Given this list of marker genes Nedd4, Pde12, Ppp2ca, Fance, Ube2e1, Tuba3b, Cdk1, Trp53, Fancg, Tubb4a, Mx2, Prkra, Ilf3, Ikbkb, Cenps, Hspa1a, Map2k6, Snca, Tubb3, Npm1, Dnajc3, Hspa8, Fancb, Eif4a1, Eif4e2 (eukaryotic translation initiation factor 4E member 2), Eif2ak2, Ube2l6, Tubb2a, Chuk, Ppp2r1a, Tuba1b, Isg15, Faap100, Faap20, Fanca, Eif4g2, Tuba4a, Eif4e3, Ikbkg, Ppp2r1b (NCBI Gene Id 73699), Ube2n, Stat3, Ppp2cb, Tarbp2, Ppp2r5a, Fancm, Eif4g3, Oasl1, Tubal3, Adar, Fancc, Tubb1, Tuba3a, Dus2 (dihydrouridine synthase 2), Rigi, Faap24, Dhx9, Ilf2, Ppm1b, Tuba8, Mapt, Cenpx, Abce1, Fancl, Mavs, Arih1, Uba7, Eif4e, Eif4a2, Hspa1b (heat shock protein 1B), Rnasel, Hspa2, Fancf, Irf3, Hspa1l, Tubb4b, Tuba1a, Tubb2b, Usp18, Flnb, Plcg1, Tubb6, Becn1, Eif4a3, Nck1, Ifit1bl2, Sphk1, Tuba1c, Trim25 (tripartite motif-containing 25), Mapk3, Ptpn2, Eif4g1, here is a description of the gene set: Antiviral mechanism by IFN-stimulated genes species: Mus musculus Mouse Gene Set: REACTOME_ANTIVIRAL_MECHANISM_BY_IFN_STIMULATED_GENES